The following is a description of a gene set: This event has been computationally inferred from an event that has been demonstrated in another species.<p>The inference is based on the homology mapping from PANTHER. Briefly, reactions for which all involved PhysicalEntities (in input, output and catalyst) have a mapped orthologue/paralogue (for complexes at least 75% of components must have a mapping) are inferred to the other species. Reactome Pathway: Base Excision Repair electronically inferred by orthology from the curated human pathway part of: DNA Repair species: Mus musculus, and this is the list of marker genes: H4c12, Pole, Rfc1, H4c8, H2bc8, Acd, Pold4, Rpa1, Lig1, H2bc12, Mutyh, H2ac8, H4c3, Nthl1, H2ax, H2az2 (NCBI Gene Id 77605), H4c2, Neil2, H2ac22, Pold2, Apex1, H4c9, Tdg, H2bc15, H2ac10, H2ac12, Mpg, Pole2, Xrcc1, H2bc9, Neil1, H2ac7, H2ac4, H2bc11, H2bc7, H4c18, H2ac20, H2ac23, H2bc1 (H2B clustered histone 1), H4c6, Pold1, H4c4, H2bc3, Terf1, Terf2, Pcna, H4c14, H2bc27, H2ac15, Mbd4, H2ac1, H4c11, H2bc13, Ogg1, H4c1, H2ac11, H2ac19, Rfc3, H2ac6, Adprs (NCBI Gene Id 100206), H2bc22, H4c17, H2ac24, H2ac13